Given this list of marker genes NR2E3, CDHR1 (NCBI Gene Id 94000), FSCN2, DHX38, SLC7A14, CFAP418, MYOC, RP9, RGR, IDH3A, DLAT, CNGA1, PRPF8, IFT172, PRPF6, CERKL, SLC6A6, CCDC28B, SDHA, RBP3, IFT140, AHI1, LRAT, PRPF31, ZNF408, ARL2BP, TUB, PRPF4, GUCY2D, IDH3B, CRX, NEK2, CLRN1, SH3TC2, RHO (rhodopsin), ROM1, RLBP1, PRPF3, GUCA1B, RP1, CC2D2A (coiled-coil and C2 domain containing 2A), PRPH2, TOPORS, USH2A, SNRNP200, RRM2B, SAG, CHM, MAK, IMPDH1, BEST1, SEMA4A, RDH5, FAM161A, AHR, POMGNT1, POU3F4, PCARE, CNGB1, OFD1, IMPG2, SPATA7, RP2, PROM1 (NCBI Gene Id 9634), EYS, TULP1, ABCA4, RPGR, EFEMP1, RPE65, CWC27, KIZ, RDH12, BBS2, ZNF513, SCAPER, CRB1, REEP6, CA4, ARL3, KIAA1549, KLHL7, AGBL5, ARL6, PRCD, RNU4ATAC, PDE6B, TTC8, IDS, ARHGEF18, IFT88, CYP1B1, LCA5, NRL, RP1L1, MERTK, PDE6G, HGSNAT, PDE6A, BBS1, DHDDS, IMPG1 (interphotoreceptor matrix proteoglycan 1), here is a description of the gene set: Human Gene Set: HP_PERIPHERAL_VISUAL_FIELD_LOSS Peripheral visual field loss Loss of peripheral vision with retention of central vision, resulting in a constricted circular tunnel-like field of vision. species: Homo sapiens